The following is a description of a gene set: Mouse Gene Set: CUI_B_CELL_IFNE_RESPONSE_DN from publication Cui A, Huang T, Li S, Ma A, Pérez JL, Sander C, Keskin DB, Wu CJ, Fraenkel E, Hacohen N (PMID 38057668) Cytokines mediate cell-cell communication in the immune system and represent important therapeutic targets. A myriad of studies have highlighted their central role in immune function, yet we lack a global view of the cellular responses of each immune cell type to each cytokine. To address this gap, the authors created the Immune Dictionary, a compendium of single-cell transcriptomic profiles of more than 17 immune cell types in response to each of 86 cytokines (>1,400 cytokine-cell type combinations) in mouse lymph nodes in vivo. A cytokine-centric view of the dictionary revealed that most cytokines induce highly cell-type-specific responses. For example, the inflammatory cytokine interleukin-1β induces distinct gene programmes in almost every cell type. A cell-type-centric view of the dictionary identified more than 66 cytokine-driven cellular polarization states across immune cell types, including previously uncharacterized states such as an interleukin-18-induced polyfunctional natural killer cell state. species: Mus musculus Genes negatively differentially expressed in cell type: B cell upon treatment with cytokine: IFN-ε in mouse lymph nodes in vivo., and this is the list of marker genes: H1f2, Jun, Fosb, Fos, Klf6, Klf2